Given this list of marker genes MSMB, DMBT1, LTF, SORBS2, TF, TMC5, IGHV3-72, BPIFB1, PROM1, PRR4, MUC5B, MS4A1, ZG16B (NCBI Gene Id 124220), BPIFA1, IGLV4-60, SLC34A2, CCL19, PRH1, PIGR, AZGP1, FOLR1, TNFRSF17, IRAG2, BPIFB2, DTNB-AS1 (DTNB antisense RNA 1), KLRB1, ABI3BP, CLU, STATH, IGLV9-49 (NCBI Gene Id 28773), HLA-DQB1, HLA-DQA1, IGHA1, TCN1, TFF3, ELAPOR1, AGR2, IGHV3-73, IGHD, SCGB3A1, here is a description of the gene set: studied in species Homo sapiens from publication Rickman DS, Millon R, De Reynies A, Thomas E, Wasylyk C, Muller D, Abecassis J, Wasylyk B (PMID 18679425) Propensity for subsequent distant metastasis in head and neck squamous-cell carcinoma (HNSCC) was analysed using 186 primary tumours from patients initially treated by surgery that developed (M) or did not develop (NM) metastases as the first recurrent event. Transcriptome (Affymetrix HGU133_Plus2, QRT-PCR) and array-comparative genomic hybridization data were collected. Non-supervised hierarchical clustering based on Affymetrix data distinguished tumours differing in pathological differentiation, and identified associated functional changes. Propensity for metastasis was not associated with these subgroups. Using QRT-PCR data we identified a four-gene model (PSMD10, HSD17B12, FLOT2 and KRT17) that predicts M/NM status with 77% success in a separate 79-sample validation group of HNSCC samples. This prediction is independent of clinical criteria (age, lymph node status, stage, differentiation and localization). The most significantly altered transcripts in M versus NM were significantly associated to metastasis-related functions, including adhesion, mobility and cell survival. Several genomic modifications were significantly associated with M/NM status (most notably gains at 4q11-22 and Xq12-28; losses at 11q14-24 and 17q11 losses) and partly linked to transcription modifications. This work yields a basis for the development of prognostic molecular signatures, markers and therapeutic targets for HNSCC metastasis. Cluster d: genes identifying an intrinsic group in head and neck squamous cell carcinoma (HNSCC). Human Gene Set: RICKMAN_HEAD_AND_NECK_CANCER_D